The following is a description of a gene set: Human Gene Set: GOCC_SMC5_SMC6_COMPLEX A conserved complex that contains a heterodimer of SMC proteins (Smc5p and Smc6p, or homologs thereof) and several other proteins, and is involved in DNA repair and maintaining cell cycle arrest following DNA damage. In S. cerevisiae, this is an octameric complex called Mms21-Smc5-Smc6 complex, with at least five of its subunits conserved in fission yeast and humans. studied in species Homo sapiens, and this is the list of marker genes: SMC5 (structural maintenance of chromosomes 5), NSMCE1, EID3, SMC6, NSMCE2, NSMCE3, SLF2, SLF1, NSMCE4A